The following is a description of a gene set: Candidate substrate proteins of AURKA. species: Homo sapiens from publication Ohashi S, Sakashita G, Ban R, Nagasawa M, Matsuzaki H, Murata Y, Taniguchi H, Shima H, Furukawa K, Urano T (PMID 16785988) Mammalian Aurora-A is related to a serine/threonine protein kinase that was originally identified by its close homology with Saccharomyces cerevisiae Ipl1p and Drosophila melanogaster aurora that are key regulators in the orchestration of mitotic events. The protein level of Aurora-A, its peak kinase activity during mitosis, and its activation have been attributed to phosphorylation. Here we show that this enzyme is an arginine-directed kinase and define its substrate specificity. We also found that Thr288 within the activation loop is a critical residue for activating phosphorylation events in vitro and that it is spatiotemporally restricted to a brief window at mitosis on duplicated centrosomes and on spindle microtubules proximal to the poles in vivo. Immunodepletion assays indicated that an upstream kinase(s) of Aurora-A might exist in mammalian cells in addition to autophosphorylation. Furthermore, human activated Aurora-A forms complexes with the negative regulator protein serine/threonine phosphatase type 1 (PP1) that was negatively phosphorylated on Thr320. Interestingly, phospho-specific Aurora-A monoclonal antibodies restrain Aurora-A kinase activity in vitro, providing further therapeutic avenues to explore. Human Gene Set: OHASHI_AURKA_TARGETS, and this is the list of marker genes: DLGAP5, TP53, MBD3, CDC25B, CENPA